Given this list of marker genes Tgm2, S100a4, Hspa8, Ighg2c, Mgarp, Jun, Fos, Dtl, H3f3b, Ngp (neutrophilic granule protein), Hspa1a, Iigp1, here is a description of the gene set: Genes up-regulated in naive T lymphocytes lacking FURIN: Cre-Lox knockout of FURIN in CD4+ cells. studied in species Mus musculus Mouse Gene Set: KRISHNAN_FURIN_TARGETS_UP West Nile virus (WNV), and related flaviviruses such as tick-borne encephalitis, Japanese encephalitis, yellow fever and dengue viruses, constitute a significant global human health problem. However, our understanding of the molecular interaction of such flaviviruses with mammalian host cells is limited. WNV encodes only 10 proteins, implying that it may use many cellular proteins for infection. WNV enters the cytoplasm through pH-dependent endocytosis, undergoes cycles of translation and replication, assembles progeny virions in association with endoplasmic reticulum, and exits along the secretory pathway. RNA interference (RNAi) presents a powerful forward genetics approach to dissect virus-host cell interactions. Here we report the identification of 305 host proteins that affect WNV infection, using a human-genome-wide RNAi screen. Functional clustering of the genes revealed a complex dependence of this virus on host cell physiology, requiring a wide variety of molecules and cellular pathways for successful infection. We further demonstrate a requirement for the ubiquitin ligase CBLL1 in WNV internalization, a post-entry role for the endoplasmic-reticulum-associated degradation pathway in viral infection, and the monocarboxylic acid transporter MCT4 as a viral replication resistance factor. By extending this study to dengue virus, we show that flaviviruses have both overlapping and unique interaction strategies with host cells. This study provides a comprehensive molecular portrait of WNV-human cell interactions that forms a model for understanding single plus-stranded RNA virus infection, and reveals potential antiviral targets. from publication Krishnan MN, Ng A, Sukumaran B, Gilfoy FD, Uchil PD, Sultana H, Brass AL, Adametz R, Tsui M, Qian F, Montgomery RR, Lev S, Mason PW, Koski RA, Elledge SJ, Xavier RJ, Agaisse H, Fikrig E (PMID 18690214)